Given this list of marker genes WSCD2, DMXL2, NPAS3, SLC35F3, DENND6A, ALDH7A1, PDK3, FMO1, RRAS, PROSER1, B4GALT5 (NCBI Gene Id 9334), PPP2R2A, RBM18, RUNX2, ZNF74, MACROD2, ZNF763, TENM3, FNDC3A, KCNQ2, PRSS35, PLCD1, F2RL2, GTF3C2, SESN2, TMTC4, SLCO4C1, CBX2, SH2D4A, ZNF697, ADAM17, SLC2A13, CACNA2D1, PCDH9, MYCBP2, TNFRSF21, HTR2A, CLOCK, MECOM, CAST, SIPA1L1 (signal induced proliferation associated 1 like 1), G3BP1, DCUN1D3, SNAP29 (synaptosome associated protein 29), LAMC1, SLC13A1, TMEM132B, UBN2 (ubinuclein 2), KCNH7, VSTM4, PIK3R1, CALCOCO1, CHMP1B, BRAP, KRBOX5 (NCBI Gene Id 124411), SIAH3, CEP85L, KLHL15, BPTF, ZNF426, BICD2, PTPRG, LRRC28, AHCYL2 (adenosylhomocysteinase like 2), PAPOLA, ZNF207, MED14, RNF157 (ring finger protein 157), BCAN, SLCO5A1, EFNA5, TSKU, SEMA5B, TYR, NRAS, UBE2B, FRAS1, GRID1, CHUK (component of inhibitor of nuclear factor kappa B kinase complex, NCBI Gene Id 1147), ATF2, NEGR1, STEAP3 (NCBI Gene Id 55240), JAG2 (NCBI Gene Id 3714), HPGD, MYO5B, BTG2, HMGCS2, ARPP21, PCDH19, ARRB1, ADISSP, EZH2, ZSCAN20, OTUB1, SKP2, ZKSCAN4, AXIN1, VAMP3, LHFPL2, ZCCHC3, C1orf105, ARPC5, SLC6A15, RAP2C, ENSG00000275993, IL7, UBE2J1, AGO1, PLXNA4, LNPK, DUSP10, MIDEAS, RAB3D, SP1, CREBRF, TNIK, CENPQ, PRR15, NQO1, CTDSP1, POGLUT1, ANO3, STX1A, MED13, USP25, PIK3IP1, GPR153, SNX4, CHST6, NR2E1, GAPT, EBNA1BP2, VPS26B, CROT, SCLT1, MBOAT2, DIP2C, SRSF8, HDAC9, LRCH4, RETREG1, CD81, FSTL4, SPTSSA, SRSF2, COL4A1, DENND4B, SLC38A10, ASF1A, NIPAL2, CCDC6, FAM98B, NUMA1, ALDH1L2, DCX, SMOX, VPS13A, LSM12, BACE1, PPP1R3B, ADCY9, RALBP1, CORO2A, MDGA2, HIPK3, ZNF124, PLEKHM3, TMEM252, NAA50, PHF8, TSPYL1 (TSPY like 1), ZNF844 (NCBI Gene Id 284391), TAFAZZIN, RAF1, SPPL2A, FOXG1, SH3KBP1, NAA15, IPO8, SERTAD2, ABHD17B, CPNE8, TTBK2, POU2F3, TIA1, PIM1, SMIM9, KIF3B (NCBI Gene Id 9371), SLC6A3, RABGAP1, FLT1, SCAI, SLC29A1, LRRC15, KRTAP13-1, TEAD1, DDX52, FRA10AC1, RTL9, TAL1, HADHA, MOCS1, GPATCH8, KLHL11, COLGALT2, NFATC2, KPNA4, PIK3C2A, FMO5, SMARCE1, SLC12A2, PGAP1, SLITRK1, SNX3, MAP3K8, ARHGEF6, RCOR1, EML4, NAV1, THNSL1, BTBD7, PIAS2, CRK, ITGA3, ADAM12, SOS1, ELAVL2, PPP1R13L, FAM120A (family with sequence similarity 120 member A), SYNJ1, WIPF2, GUCY1A2, ARK2C (NCBI Gene Id 494470), DENND2B, CPD, GAB2, GPR63, ATL2, ITM2C, KL, ZBTB41, ARRDC3, INSYN2A, EBF3, NAP1L5, FAM199X, GFM2, ENAH, ZNF268, VAT1, CAV1, ZNF451, CSMD3, MTM1, RIC3, TP53INP1 (tumor protein p53 inducible nuclear protein 1), ZBTB20, here is a description of the gene set: Genes predicted to be targets of miRBase v22 microRNA hsa-miR-605-3p in miRDB v6.0 with MirTarget v4 prediction scores > 80 (high confidence targets). studied in species Homo sapiens Human Gene Set: MIR605_3P from publication Chen Y, Wang X (PMID 31504780)